Given this list of marker genes SRC, WNT7A, GREB1L, HOXA11, LHX1, ESR1, ASH1L, WNT5A, LHCGR, SMAD4, CDKN1C, COL6A1, WNT9B, NIPBL, TGFB2, CYP19A1, HOXA9, GATA3, KDM5B, RBP4, STRA6, HOXA10, MYOCD, FOXL2, CITED2 (Cbp/p300 interacting transactivator with Glu/Asp rich carboxy-terminal domain 2), ERRFI1, ANTXR2, FSHR, here is a description of the gene set: species: Homo sapiens The reproductive developmental process whose specific outcome is the progression of the uterus over time, from its formation to the mature structure. Human Gene Set: GOBP_UTERUS_DEVELOPMENT